Given this list of marker genes APIP (APAF1 interacting protein), CALHM6, POP7, PDE4DIP, BAALC, HMGCS1, SPCS3, MIR3648-1, SUSD5, DUSP7, NSMCE4A, LSM5, MAEA, ATRX, ADAMTS1, SLC29A1, LAP3, SMARCA5, KAT2B, HCCS, HDDC2, MTERF3, PALMD, APBB2, PDS5A, NCAPG, NAA15, GAR1, TMEFF1, FADS2, PLK2, COX5A (cytochrome c oxidase subunit 5A), EIF4G3, NTN4, SFXN1, NDUFV2 (NADH:ubiquinone oxidoreductase core subunit V2), GLRX2, MAGEA12, RGS20, CAVIN2, SRM, RNF138 (NCBI Gene Id 51444), SHTN1 (shootin 1), PNN, FGF12, HPF1, GRTP1, PDLIM5, MTOR, SEMA3C, S100A8, TSPAN13, DUSP6, TFDP1, C15orf48, KYNU, TRABD2A, HERC2P9, NOC2L, GRPEL1, DIO3, CD70, TBRG4, MRPL13, CASD1, MAP7D2, SMC3, SMN1, FAM216A, SAC3D1, AURKA, SHOC2, ZFPM2, SMS, DEF8, CDC42, HLA-B, SLC25A37, CTPS1, SMG1P5, MAGEA1, PRDX3, MXRA5, PTP4A1, MICA, SLC16A2, KBTBD11, CAV1, LOXL1, TPD52, SLC4A7, SLITRK5, DLEU2, OAS3, HAUS6, CXCL3, LBR, EBP, AK2, TGM2, MAGEA5P, TFPI2, MATCAP2, PLCB4, TBC1D4, DBNDD2, ADAM12, RAB9A, RBFOX2, SLC1A6, SCML1, MIOS, MRS2, NUDC, WNT5B, CXCL8, QDPR, TNFRSF6B, BMP2K, ERCC6L, BST2, INPP4B, NMT2, BBIP1, TSTD1, USP6, HSPA1A, CXCL5, ARSJ, ANXA2R-OT1, TPM1, CAV2, IDH3A, DUSP9, LIF, POLR3G (NCBI Gene Id 10622), TXNL4A, IL13RA2, EIF1AX, BOLA2, GUCY1A2, TLE4, GTF2A2, FGF2, B3GALNT1, MX2, TM4SF18, NPIPB3, GOLGA8A, CCNE2, GASK1B, GAL, LBHD1, HSPH1, MAPK6, EXOSC8, AP2B1, OPN3, PRSS23, CACYBP, NPTX1, POU4F1, FGF5, TEX30, GALNT14, LY6E, PWP1, SACS, BAMBI, HNRNPD, CELF1, SAMHD1, PDCD2, TMEM33, MX1, CDC25A, FIP1L1, ATAD3A, TMEM14B, SLCO4A1 (NCBI Gene Id 51737), UCHL1, TWIST1, AFF3, EPHA2, CDCP1, GLA, AIMP1, ZNHIT1, TLCD4, STEAP3, ELOVL6, UBE2V2, OR7E12P (olfactory receptor family 7 subfamily E member 12 pseudogene), IFT25, DYNLT3, WWC3, SRGN, HSPA1B, ETV3, NT5E, RWDD3 (RWD domain containing 3), SPON2, HADH, NRG1, TMEM47, ATP5ME, PSMB8, TNFRSF11B, MED28 (NCBI Gene Id 80306), BDKRB2, CYYR1, BNIP3, ENOPH1 (NCBI Gene Id 58478), TARDBP, ALAS1, HIGD1A, STAM, ADAMTS2, LGALS3BP, PPIF, CYP1B1, PNISR, HSPA9 (heat shock protein family A (Hsp70) member 9), LAMA4, PPA2, C11orf24, GNL3, APOO, SGK1, ABI3BP, TAP2, GNG11, ITGA10, MOK, CAND2, CITED2, EXOSC10, TRIM8, GLYR1, FOCAD, NOP16 (NCBI Gene Id 51641), TCERG1, SRPK1, ADGRL2, PDLIM3, DVL1, DCK, GLT8D1, RNF182, NDUFAF3, PRR7, RASA1, CKLF, LYPLA1, FJX1, SOD2, PPP4R4, GDF15, SFRP2, MRPS17, C1QBP, CCNE1 (NCBI Gene Id 898), PBK, PDCD5, SLBP, TNFRSF21, RNF6, UCHL5, SUCLA2, SACM1L, NUP58, ZNF45, ABCE1 (ATP binding cassette subfamily E member 1), E2F5, SHISA2, DUSP4, SIX2, TACC2, CCR8, SELENOW, GLRX3, LINC01399, DNAJC15, PLAGL1, SCG2, HSPA4L, CSTB, HACD1, VPS4B, GALNT7, BDKRB1, CFAP299, TRIM9 (NCBI Gene Id 23206, tripartite motif containing 9), RP2, HS3ST1, FANCI, CXCL2, AASDHPPT, PRDX2, WFDC21P, CXCL6 (NCBI Gene Id 6372), IL4R, DLAT, ABHD3, SORBS2, CASP7, SLC39A8, AKR1B1, NDUFAB1, PTGER4, PDF, ATP2B1, SEPTIN9, RAMP1, CXCL1, FH, DOCK1, PSMB9, TMSB4Y, MACROH2A1, AFG2B, CSAG3, S100A2, CREB3, TIAL1, TRPC4, TPD52L1, MID1, MAGEA3, RSPO3, CSTF3 (cleavage stimulation factor subunit 3), MYBL1, EHD4 (NCBI Gene Id 30844), COX7B (NCBI Gene Id 1349), PARP12, HMGA1, TM4SF1, SNRPA1, SMURF2 (SMAD specific E3 ubiquitin protein ligase 2), PDHA1, IER5, HSPA4, PRR16, SMG1P2, ZNF385D, MEF2A, SDHB, RGS4, MAD2L1, CTSC, IFT74, B3GNT5, VRK1, TAP1, RRAS2, EGFR, MTAP, PRAME, OSTM1, SERF1A, BDNF, ACOT9, GTF2H2, HPSE, HK2, MAN1A1, CAT, DENND2A, SERF2, TRIB1, EIF4E, IGF2BP3, DRAP1, NDC80, CD9, CLK4, OGFRL1 (NCBI Gene Id 79627), ARGLU1, CSE1L, CENPV, CYB5B, PIGA (NCBI Gene Id 5277), STC2, IFI27, BST1, ING2, here is a description of the gene set: Human Gene Set: WANG_SMARCE1_TARGETS_DN from publication Wang L, Baiocchi RA, Pal S, Mosialos G, Caligiuri M, Sif S (PMID 16135788) Genes down-regulated in BT549 cells (breast cancer) by expression of SMARCE1 off a retroviral vector. studied in species Homo sapiens Mutation of BRG1, hBRM, and their associated factors, INI1 and BAF57, in primary human tumors has suggested that inactivation of human SWI/SNF (hSWI/SNF) complexes may be involved in neoplastic transformation. BT549 is an invasive human breast carcinoma cell line that lacks expression of BAF57, a key hSWI/SNF subunit that mediates interaction with transcriptional activators and corepressors. In this study we investigated the role of BAF57 in suppressing tumorigenesis by establishing BT549 stable cell lines that expresses full-length BAF57 protein. BT549 clones expressing BAF57 demonstrated marked phenotypic changes, slow growth kinetics, and restoration of contact inhibition. Altered growth was found to be due in part to cell cycle arrest and induction of apoptosis. Furthermore, microarray analysis revealed that BAF57-mediated cell death was associated with up-regulation of proapoptotic genes including the tumor suppressor familial cylindromatosis (CYLD), which was found to be a direct target of BAF57 as determined by chromatin immunoprecipitation analysis. Increased expression of CYLD in BT549 cells induced apoptosis, while its suppression by small interfering RNA inhibited cell death in BAF57 expressing BT549 cells. These findings demonstrate the importance of BAF57 in cell growth regulation and provide a novel link between hSWI/SNF chromatin remodelers and apoptosis.